Given this list of marker genes RUFY2, NSMAF, ITPKB, NOTCH2, IL5RA, LGR4, CACNA1B, CYRIA, TEAD3, CENPF, INPP1, PPP6C, SWAP70, UBE2H, RHOBTB3, BCL6, BCL2A1, ITSN1, PLA2G5, ORAI2, CBX2, SEC14L1, SDCBP, MAP1LC3C, USP6NL, ADGRE2, GHSR, H3-3B, ADGRE3, GNAQ, GLRB, ERP44, ITPRID2, CAMK1D, TNP2, ALDH3B2, C2orf72, CALM1, TTYH1, JAK2, AHR, FES, FAM131A, SGK1, NRBF2, HLA-B, SLC4A8, ZNF200, TTC9, OR3A3, WFDC1, THBS1, ENTPD1, CRK, RBPJ, ZNF460, DNAJC7, GPR137B, LST1, HRH2 (histamine receptor H2), MAST1, PIK3CB, RERGL, RAB3GAP1, SMS, TAOK3, MYL6, RXRA, CNR2, USP22, SNTB1, CFD, TBX1 (NCBI Gene Id 7413), KRT33A, CHP1, ANPEP, PTX3, S100P (NCBI Gene Id 6286), LHX6, PNRC1, BRCA1, C2orf68, LTB, EGLN1, CYSLTR1, E2F3, EEIG1, SLC19A1, BTF3P12, RTN3, THYN1, BIK, SH2B2, LONP2, DDX6, DDX21, UBE2B, MFSD1, ACSBG1, CYP1A1, ADAM8, DCUN1D2, LRP5L, MCL1, INPP5A, TMEM127 (NCBI Gene Id 84178), NAA60, SVIL, ACP3, ADAM29, ARHGAP26, MTM1, PRODH, SEC62, HOXB6, RRAGD, KERA, VCAM1, MKRN1, SEMA6C (semaphorin 6C), RSL24D1, CCNH, SLA (Src like adaptor), BANP, CHMP3, DARS1, STK4, SNN, CENPU, SOHLH2, TREML2, REPS2, GRB10, CDC14B (cell division cycle 14B), FXYD1, PLXNC1, EIF4A3, LMOD1, SRRM2, MARCHF3, BARX2, ERLIN2, PGK1, DHX9-AS1, AREG, PTGS1, TLR7, EFNB2, PYGL, CNBP, SKP2, ZMIZ1, MSLN, ALOX5, TNFSF14, RSAD2, SLC26A1, ENOSF1, GLRX, SLC6A6, NFIL3, LSM14B, CKAP4, NCOA4, ALOX15, OLIG2, ITM2B, PSMD12, TMEM248, TMEM212, ZNF3, ESRP2, XPO6, ASAH1, MAD2L1BP, NEAT1, MTCP1, BTBD7, ZNF281, PDCD4-AS1, RNF24, HNRNPUL1, CYB5R4, PTH1R, LIMK2, RGS1, FTH1, SAP30L-AS1, CMTM6, MTHFR, EPM2AIP1, VPREB1, NDUFA6, FRAT1, JAG1, PIK3CG, TMEM156, FNBP1L, here is a description of the gene set: Human Gene Set: GSE3982_EOSINOPHIL_VS_NKCELL_UP studied in species Homo sapiens from publication Jeffrey KL, Brummer T, Rolph MS, Liu SM, Callejas NA, Grumont RJ, Gillieron C, Mackay F, Grey S, Camps M, Rommel C, Gerondakis SD, Mackay CR (PMID 16474395) In the present study we used Affymetrix oligonucleotide microarrays to produce gene transcription profiles for the major leukocyte types in humans. This comprehensive dataset enabled us to not only establish which genes were expressed in each leukocyte type, but also which genes were expressed in each subset after activation. The used of a comprehensive dataset of gene profiles from all the major human leukocyte subsets enabled a novel and powerful means for identification of genes associated with single leukocyte subsets, or different immune paradigms. Genes up-regulated in comparison of eosinophils versus NK cells.